The following is a description of a gene set: Human Gene Set: KEGG_MEDICUS_VARIANT_EML4_ALK_FUSION_KINASE_TO_PI3K_SIGNALING_PATHWAY Pathway Definition from KEGG: EML4-ALK -> PI3K -> PIP3 -> AKT -| BAD EML4-ALK fusion kinase to PI3K signaling pathway. Pathway ID: N00047. Pathway type: Variant. Pathway class: nt06266 Non-small cell lung cancer. species: Homo sapiens, and this is the list of marker genes: ALK, AKT2, PIK3CB, AKT3, AKT1, PIK3CA, PIK3CD, BAD